Given this list of marker genes ATP6V0B, GPR146, ADA, CIAO2B, HHIP, POLR2E, ID2, SOCS6, PCDHB12, RNF19B, WIPI1, IFI35, HBG2, RNASE3 (NCBI Gene Id 6037), SLAMF1, CNTLN, METRNL, MAGI3, NUFIP1, BCL2L11, RHOH, TXNRD1, RNPS1, ZNF264, CBLC, ARID5A, MMP11, PIM1, IL15RA, DOP1B, PIM2 (NCBI Gene Id 11040), BAG2, HIF1A, CLDN10, SFRP2, RASAL2, DAB2, FAM227B, CHD4, HEPH, SOCS1, NAGK, IL1RL1, PADI4, SCNN1G (NCBI Gene Id 6340), PHYHD1, TFAP2A, CATSPERG, RNF19A, DHX57, ELP5, JUNB, NEK2, GAB3, ERG, RAPGEF6, SOCS3, SECISBP2L, HOOK2, FAM118B, MYD88, PRAMEF2, SGTB, PRSS58, MAP4K1, GPX4, TTC39B, PCLO, SLC35D1, PTPN4, KPNA1, VPS54, ZBTB11-AS1, GSX2, TLL2, NABP1 (nucleic acid binding protein 1), TXNL4A, CDKN1A, STX1B (NCBI Gene Id 6805), PRDM1, BMP6, SLC25A19 (solute carrier family 25 member 19), CAPZB, BMX, PARP14, ELOVL6, PELO, BTG1, OLFM3, BATF, GPC6, HSD17B13, DFFA, TNFRSF18, TNFAIP2 (TNF alpha induced protein 2), RGS1, NUP43, LCMT2, ERBB4, ARSI, PDHA2, MARVELD2 (NCBI Gene Id 404087), IL36G, EXO1, TSPAN12, KY, CACNA1C, IFNG, TTYH1, CRTC3, KCNA1, KRTAP13-2, FES, EIF5A, UNC119, MYORG, LDB2, OTULIN (OTU deubiquitinase with linear linkage specificity), KCNAB3, CUX1, IFT70A, ELAC2, IGLL1, PLA2G12B, PRXL2B (peroxiredoxin like 2B), SLC6A18, CRLF2, GSDMA, CHCHD10, PARD6B, MOXD1, JUND, PLK3, AFF2, PGP, OSBPL9, NSMCE1, TMEM140, BCL3, PRKG1, RAB18, CADPS, JAM3, CDKN2D, IL33, KRTAP19-3, INPPL1, PRDM4, KRTAP8-1, ADCK1, MSRB1, BCL2, LYSMD1, PWP2, NRK, IRF1, PJA1, ZSCAN12, MFGE8, CSF2RA, EEIG1, RPS4X, C3orf38 (NCBI Gene Id 285237), HGSNAT (heparan-alpha-glucosaminide N-acetyltransferase), ANKRD40, TRAPPC2L, MPP7, CXCL10, PARP9, IL13, GADD45G, PLEKHO1, SBF2, STC1 (NCBI Gene Id 82914), EVX1, IL4R, STAT1, PIP4K2B, CISH, CAMK1G, SYCP3, C21orf91, TXNRD3, SLC39A13, ZC2HC1C, SDCCAG8, LDHA, SEZ6, TMBIM1, DPYD, CCNE1, MYBL1, PABPC4, PPP1R8, XCR1, USH1C, MAK (male germ cell associated kinase), PPP1R14C, RNF114, TNFSF8, here is a description of the gene set: Human Gene Set: GSE36527_CD62L_HIGH_CD69_NEG_VS_CD62L_LOW_CD69_POS_TREG_KLRG1_NEG_DN Thymic-derived natural T regulatory cells (nTregs) are characterized by functional and phenotypic heterogeneity. Recently, a small fraction of peripheral Tregs have been shown to express Klrg1, but it remains unclear the extent Klrg1 defines a unique Treg subset. Here we show that Klrg1+ Tregs represent a terminally differentiated Treg subset derived from Klrg1- Tregs. This subset is a recent antigen-responsive and a highly activated short-lived Treg population that expresses enhanced levels of Treg suppressive molecules and that preferentially resides within mucosal tissues. The development of Klrg1+ Tregs also requires extensive IL-2R signaling. This activity represents a distinct function for IL-2, independent from its contribution to Treg homeostasis and competitive fitness. These and other properties are analogous to terminally differentiated short-lived CD8+ T effector cells. Our findings suggest that an important pathway driving antigen-activated conventional T lymphocytes also operates for Tregs. Gene expression analysis was performed of this and other Treg subsets based on expression of CD62L, CD69, and Klrg1 to define the molecular properties of Klrg1+ Tregs and its relationship to other Treg subsets found in the peripheral immune tissues. Genes down-regulated in KLRG1- T reg:SELL high CD69- versus SELL low CD69+. species: Homo sapiens from publication Cheng G, Yuan X, Tsai MS, Podack ER, Yu A, Malek TR (PMID 22786769)